The following is a description of a gene set: Any process that modulates the frequency, rate or extent of NADP metabolic process. studied in species Homo sapiens Human Gene Set: GOBP_REGULATION_OF_NADP_METABOLIC_PROCESS, and this is the list of marker genes: MLST8, RPTOR, ALDOB, TIGAR, MTOR, ME2 (NCBI Gene Id 4200), TP53, ME1